Given this list of marker genes Nckap1l, Nuak2, Pla1a, Cd274, Plgrkt, Bcl2l11, Sphk1, Slc3a2, Pik3r5, Tcf4, N4bp2l1, Stat4, Atp6v0a1, Pdcd1lg2, Vdr, Rad21, Runx3 (NCBI Gene Id 56483), Basp1, Nrip1, Ccl17, Nae1, Ccnd2, Cyfip1, Coro2a, Psma3, Noct, Zfp398, Pik3r1, Ifi47, Xbp1, Glipr2, Plekha1 (pleckstrin homology domain containing, family A (phosphoinositide binding specific) member 1), Acadm, Gpbp1, Fchsd2, Zbtb18, Casp4, Pacsin2, Csrp1, Ptger4, Cd86, Plk2, Galnt7, Cish, Slfn2, Stxbp6, Rgs12, Bzw1, Tmem131l, Txnrd1, Crem, Ccr7, Acsl5, Pkib, Nrp2, Fscn1, Eif4a1, Ggta1, Id2, Iscu, Gbp5, Psd3, Rras2, Prdm1, Tpm4, Mir155hg, Sh3pxd2b, Cyrib, Nr4a3, Hax1, Psma6, Mrtfa, Picalm, Ptpn1, Phlpp1, Txn1, Odc1, Apaf1, Pde4b, Tmem70, Calcrl, Nfkbia, Bcl7c, Calm1, Map4k4, Il10ra, Pdcd4, Nfil3, Prps1, Tmed5, Cd63, Mefv, Dph5, Nup88, Tes (testin LIM domain protein), Cytip, Iqgap1, Stat1, Riok3, Mkrn1, Cst3, Abracl, Bcl2l14, Itga4, Ncoa7, Rabep1, Cd200, Trim25, Lgmn, Zyx, Pfkfb3, Stxbp3, Actr3, Anxa2, Mt2, St8sia4, Sptbn1, Nupr1, P2ry10, Cd302, Irf5, Cacna1s, Gramd2b, Jak2, Serpinb6b, Sema7a, Ifitm2, Ldha, Adprh, Lrrfip1, Map3k14, Cd82 (NCBI Gene Id 99148), Jaml, Cdkn1a, Kif3b, Igfbp4, Litaf, Tmbim4, Psen2, Cd80, Rufy3, Nrros, Gadd45g, Il15ra, Abtb2, Epb41, Tmem131, Pdlim5, Slc27a3, Rap2a, Snx10, Irgm2, Actn1, Ktn1, Mapre2, Ly75 (NCBI Gene Id 17076), Clic4, Pnp, Lactb, Etv6, Adgrg6, Fth1, Cfl1, Bcl3, Nfkb1, Cnn3, Wnk1, Srgn, Il7r, Ikzf4, Il1b, Serpinb9, Macroh2a1, Tmbim1, Tspan13, Akap9, Atp11a, Stk24, Plekhg2, Pim1, Zbtb38, Flnb, Sik3, Stat3 (NCBI Gene Id 68733), Sh3bgrl, Ehd1, Plscr1, Bcl2a1b, Tbc1d8, Ccl22, Selplg, Syngr2, Rin3, Mif4gd, Got1, Bcl2a1d, Cebpb, Rab8b, Hcls1, Bbx, Socs1, Kif21b, Ifi35, Rasa2, Aldh1a2, Serpina3g, Eloc (NCBI Gene Id 98484), Rel, Samhd1, Ramp3, Ubxn2a, Arid5a, P2rx4, Foxn3, Eif1a, Ndrg1 (N-myc downstream regulated gene 1), Ccdc71l, Ahnak, Npr1, Chd7 (chromodomain helicase DNA binding protein 7), Orai1, Aff1, Cox17, Gpcpd1, here is a description of the gene set: from publication Cui A, Huang T, Li S, Ma A, Pérez JL, Sander C, Keskin DB, Wu CJ, Fraenkel E, Hacohen N (PMID 38057668) Genes positively differentially expressed in cell type: MigDC (migratory dendritic cell) upon treatment with cytokine: IL-1β in mouse lymph nodes in vivo. Cytokines mediate cell-cell communication in the immune system and represent important therapeutic targets. A myriad of studies have highlighted their central role in immune function, yet we lack a global view of the cellular responses of each immune cell type to each cytokine. To address this gap, the authors created the Immune Dictionary, a compendium of single-cell transcriptomic profiles of more than 17 immune cell types in response to each of 86 cytokines (>1,400 cytokine-cell type combinations) in mouse lymph nodes in vivo. A cytokine-centric view of the dictionary revealed that most cytokines induce highly cell-type-specific responses. For example, the inflammatory cytokine interleukin-1β induces distinct gene programmes in almost every cell type. A cell-type-centric view of the dictionary identified more than 66 cytokine-driven cellular polarization states across immune cell types, including previously uncharacterized states such as an interleukin-18-induced polyfunctional natural killer cell state. Mouse Gene Set: CUI_MIGDC_IL1B_RESPONSE_UP species: Mus musculus